The following is a description of a gene set: studied in species Mus musculus Long distance growth of a single dendrite involved in cellular development. Mouse Gene Set: GOBP_DENDRITE_EXTENSION, and this is the list of marker genes: Plaa, Syt1, Pten, Stk11, Smurf1, Cpne5, Cpne6, Wasf1, Rasal1, Mecp2, Atg16l1 (autophagy related 16 like 1), Prkn, Spag9, Bcl11a, Sh3gl2, Cdkl3, Cxcr4, Rims1, Reg1, Llph, Auts2, Slc23a2, Sh3glb1, Syt2, Cyfip2, Slc9a6, Syt3, Rims2, Unc13a, Tmem108, Mul1, Hnrnpk, Itsn2, Ostn, Rnf157, Nedd4l, Syt4, Syt17, Afdn, Cyfip1 (NCBI Gene Id 29878), Wnt5a, Cpne9, Bdnf, Picalm (NCBI Gene Id 233489), Cacng7